The following is a description of a gene set: The directed movement of a monoatomic anion, into, out of or within a cell, or between cells, by means of some agent such as a transporter or pore. Monatomic anions (also called simple anions) are negatively charged ions consisting of exactly one atom. species: Homo sapiens Human Gene Set: GOBP_MONOATOMIC_ANION_TRANSPORT, and this is the list of marker genes: SLC17A7, GABRA6, SLC4A3, CLIC3, SLC13A1, GABRB1, BEST3, TTYH3, SLC5A1, P2RY4, CLIC1, SLC19A1, CLDN4, GABRD, TMC4, TTYH1, CLNS1A, LRRC8E, PANX1, ANO4, CLCNKA, TG, SLC4A2, SLC26A6, GABRG1, LRRC8A, MCOLN3, SLC26A4, ABCC6, GLRB, ANO9, SLC17A3, GABRE, GABRR2, P2RX5, GABRB3, ABCC11, ABCC1, ABCB1, CLCA2, PACC1, SLC26A11, TRPA1, CA2 (NCBI Gene Id 760), FXYD3, GABRP, CLCN5 (chloride voltage-gated channel 5), GLRA3, VDAC3, SLC4A9, SLC4A5, SLC26A10P, PDZK1, GPR89A, GABRA1, SLC4A8, CLDN17, ANO6, SLC39A14, SLC12A7, ANO5, ABCC9 (NCBI Gene Id 102724274), RAB11B, SLC4A10, SLC1A3, VDAC1, APOL1, BEST4, UCP2, ABCC2, CLCN6, BEST1, ATP8B1, CLIC5, KCNQ1, MCOLN1, ANO2, ABCC3 (ATP binding cassette subfamily C member 3), BSND, SLC22A6, SLC4A1, GOPC, SLC1A2, SLC1A1, PRKG2, SLC26A3, SLC4A11, CLCN1, SLC25A14, GABRQ, GABRR1 (gamma-aminobutyric acid type A receptor subunit rho1), SLC12A6, DCD, GABRB2, TSPO, SHOC2, LRRC8D, CFTR, SLC12A3, LRRC8C (NCBI Gene Id 84230), STC1, VDAC2, TCAF1 (NCBI Gene Id 9747), SLC5A5, GABRA4, OSTM1, SLC26A8, SLC26A7 (solute carrier family 26 member 7), AQP6 (NCBI Gene Id 363), SLC4A4, BEST2, CA7, CLCA4, SLC17A6 (solute carrier family 17 member 6), CCT8L2, SLC12A2, NMUR2, SLC1A4, CLIC4, CASR, GPR89B, SLC6A14, SLC1A7, SLC26A5, WNK4, SLC17A5, ANO3, GLRA2, CLIC6, SLC12A9 (solute carrier family 12 member 9), LRRC8B, SLC6A2, SLC5A8, GABRA3, ANO10, CLCN3, GABRA2, CLCC1, SLC26A1, SLC12A8, GABRG3, ABCC4, SLC26A2, ANO7, SLC6A1, CLCA1, AHCYL1, SLC12A1, SLC17A8, KCNK2, MFSD8, CLCN4, NMUR1 (neuromedin U receptor 1), ANO8, GABRR3, GABRA5, TCAF2, CLIC2, SLC26A9, ANO1, P2RY6, CLCNKB, SLC25A27, SLC4A7, ABCC10, GABRG2 (NCBI Gene Id 2566), SLC12A4, FXYD1, CLCN2, SLC12A5, OCA2 (OCA2 melanosomal transmembrane protein), KCNK1, ABCC5, CLCN7, SLC5A6, TTYH2, GLRA1